The following is a description of a gene set: Any process that activates or increases the frequency, rate or extent of glial cell migration. species: Mus musculus Mouse Gene Set: GOBP_POSITIVE_REGULATION_OF_GLIAL_CELL_MIGRATION, and this is the list of marker genes: Rras2, Cx3cl1, Grin1, Ptprz1, Trem2, P2ry12, Lrp1, P2rx4, Fubp1, Ccr2, Tiam1, Crkl, Cx3cr1, Csf1